The following is a description of a gene set: A major challenge for kidney transplantation is balancing the need for immunosuppression to prevent rejection, while minimizing drug-induced toxicities. We used DNA microarrays (HG-U95Av2 GeneChips, Affymetrix) to determine gene expression profiles for kidney biopsies and peripheral blood lymphocytes (PBLs) in transplant patients including normal donor kidneys, well-functioning transplants without rejection, kidneys undergoing acute rejection, and transplants with renal dysfunction without rejection. We developed a data analysis schema based on expression signal determination, class comparison and prediction, hierarchical clustering, statistical power analysis and real-time quantitative PCR validation. We identified distinct gene expression signatures for both biopsies and PBLs that correlated significantly with each of the different classes of transplant patients. This is the most complete report to date using commercial arrays to identify unique expression signatures in transplant biopsies distinguishing acute rejection, acute dysfunction without rejection and well-functioning transplants with no rejection history. We demonstrate for the first time the successful application of high density DNA chip analysis of PBL as a diagnostic tool for transplantation. The significance of these results, if validated in a multicenter prospective trial, would be the establishment of a metric based on gene expression signatures for monitoring the immune status and immunosuppression of transplanted patients. studied in species Homo sapiens from publication Flechner SM, Kurian SM, Head SR, Sharp SM, Whisenant TC, Zhang J, Chismar JD, Horvath S, Mondala T, Gilmartin T, Cook DJ, Kay SA, Walker JR, Salomon DR (PMID 15307835) Genes down-regulated in kidney biopsies from patients with acute transplant rejection compared to the biopsies from patients with well functioning kidneys more than 1-year post transplant. Human Gene Set: FLECHNER_BIOPSY_KIDNEY_TRANSPLANT_REJECTED_VS_OK_DN, and this is the list of marker genes: HNMT, FMR1 (fragile X messenger ribonucleoprotein 1), SERINC1, SLC16A4, DNPH1 (NCBI Gene Id 10591), AHCYL1, CDKN1C, CLIC4, AKR1C3, SLC17A1, PHKB, RTL8C, DYNLT3, ENPP2 (NCBI Gene Id 5168), RBP4, SLC5A3, R3HDM2, KRIT1, ARMCX2, SELENBP1, DLEU1, SLC4A4, PALM2AKAP2, RNF6 (NCBI Gene Id 6049), ZNF124, IMMT, DDOST, ETFA, STRAP, ABCC4, USP14, PGRMC2, SLC34A1, PTPRD, G3BP1, HSD11B2, CYB5R3, ALDH4A1, PCBD1, GBE1, DPYS (dihydropyrimidinase), CAT, NEK4, SMG1, FMO1, PTPN3, HIBCH, CTSL, MAPK1IP1L, GLYAT, EBNA1BP2, UQCRQ, VDAC1, PRKRA, RAB29, GTF2I, PRPSAP2, CRYAA, KL, ALDH3A2, SERBP1, PEX19, BTBD3, ABCB1, PPP2R3A, SLC31A1, ATP6V0E1, KCNJ15, MFAP3L, TMED10, VTI1B, GLUD2, CFDP1, RAB2A, IGFBP5, HDGF, PRODH2, SLC22A6, CA12, DNM1L (dynamin 1 like), UQCRC1, SALL1, RBPMS (NCBI Gene Id 11030), ATP5F1A, NR1D2, RRAS2, CDC42BPA, SHANK2, AHCY, ZNF148, MMUT, HSPA4, ACY1, H2AZ2 (NCBI Gene Id 94239), CRYAB, GCDH, COX7A1, AZGP1, SOD1, CLASP2, ABCD3, GCHFR, SH3BGR, PMPCB, STRN3, SLC13A3, ECHS1, TNFRSF11B, ATF2, GSTA1, COBLL1 (NCBI Gene Id 22837), HSPD1, ZBTB20, NONO, HSPA8, LARP4 (NCBI Gene Id 113251), PHYH, ESRRG (NCBI Gene Id 2104), AIFM1, PTH1R, SNX2, SMAD4, APOM, ADGRF5, PARD3, ACO1, MRPS18B, PDZRN3, GLOD4, LGALS2, AKR7A3, GATD3, MAF, TERF1, PLPBP, AKR1A1, SLC17A3, ASAP2 (ArfGAP with SH3 domain, ankyrin repeat and PH domain 2), DNAJB9, PRKAR1A, PPM1B, SDHC, CCNG2, GLDC, PCK2, UGT8, ATP6V1A, ENOSF1, GOLGA4, CYP4A11, TMBIM6, BNIP3, FAM169A (NCBI Gene Id 26049), DDX19B, BHMT, HPGD, SEC23A, PTGER3, IGSF3, GRB10, FPGT, UBE2E3, NDUFS4, HADH, ZDHHC17, UGDH, SERPINA5, MME, TST, CSNK2A1, ALDH2, NDUFAB1, DZIP1, VAT1, ALDH9A1, ALB, ACOT13, GHITM, SLC27A2, CYB5A, KHK, TECR, DDX10, GCSH, MARCHF6, PLAAT3, CAP2 (cyclase associated actin cytoskeleton regulatory protein 2), GULP1 (GULP PTB domain containing engulfment adaptor 1), MSMO1, RIDA, MAOA, COPS2 (NCBI Gene Id 9318), SPTSSA, ENTPD5, SORD, CBR4, UGT2B15, YES1, DMXL1, SNRPN, FUCA1, MYO6, CENPS, COL4A4, ALDOB, KIF3A, MXI1, CLTB, HSPA13 (NCBI Gene Id 6782), DUSP3 (dual specificity phosphatase 3), NR3C2, UBA1, UGT2B7, CRYM, PFN2, PAFAH1B1, ACADSB, ADH5, ITGA6, HAGH, APLP2, SYPL1, SDHA, BEX4, NCKAP1, TOMM34, SLC25A36, PIK3C2A, AUTS2, HSPA4L, GOT1, GPD1L, ABCC6, EXPH5, ENPEP, GSTA2, CA4, FABP1, PODXL, COPS5, AGL, HSPB1, SCAMP1, PARG, USP2, SLC22A2, SCP2, SULT1C2, SLC1A1, PRDX3, RTN4, PPP2R1A, SLC25A4, LRP2, AOC1, MAOB, TNPO1, SDC1 (syndecan 1), FKBP2, ACOX1 (acyl-CoA oxidase 1), CALM1, OCLNP1, PCCA, ACSM2A, ACAA2, DSP, AQP1, RPS6KA3, HSPE1, KIF3B, ANK2, GLRX, SLC25A13, RAB1A, ACVR1B, SDHB, SETD3, SLC7A8, CYP4F2, EFHD1, ACO2, ANXA7, SEPHS2, WEE1, MYH10, PDLIM5, PRPF40A, GABARAPL1, ATP5PF, RNASE4, PEX11B, FBXO21, HPD, PLS3, SRSF1, PHB1, AP3D1, EIF1AX, MT1G, ERBB4, ANK3, CLDN8, ITM2B, PSMD11 (proteasome 26S subunit, non-ATPase 11), AQP3, WWTR1, UGT1A10, ASS1, ABCC2, PLEKHB2, ATP5PO, VEGFA, EPS8, CNIH1, MIA2, FYN, SNX4, ABAT, BLTP1, DDT, IDH1, PEX7, KANK1, MTMR4 (myotubularin related protein 4), PEPD, RFK, PDHX (pyruvate dehydrogenase complex component X), UFL1, TXN, NDUFS1, F2R, OAT, CDS1, MDH1, RPP14, CLINT1, PDZK1IP1, PDXDC1, PCK1, GJB1, ACP3, ACAA1, ESD, HMGCL, SC5D, NDUFA5, IGFBP4, KBTBD11, HGD, AGAP1, EPCAM, FECH, DDC (dopa decarboxylase), PDZK1, AKAP11, NREP, COX11, NDRG1, NQO2, SLC39A14 (NCBI Gene Id 23516), FAH, LRPAP1, RHOBTB1, MORF4L2, MTSS1, GRHPR, FBP1, GATM, PPP2CB, YWHAE, CYP3A5, SCAF11, NAT8, MPC2, IDH2, SLC16A7, FAM3C, TRIM44, PEBP1, SEPTIN10, OGG1, NARS1, TEK, MYH11, PEX3, MINPP1, DSTN, ERBB3, QPRT, TMED5, RGN, BBOX1, CTH, PRKCA, FGF9, TOMM70, GLS, DPP4, MICU2, AUH, AK4, TOMM20, IGF1R, EIF3I, SERPINI1, PGRMC1, COPA, PUM1, HPN, ANPEP, PJA2, LRPPRC, RNF14, COX6A1, PRDX2, TOX3, GGT1, PARM1, AFM, SRRM1, RHOBTB3, AKR1C1, RCAN1, PAH, CDK14, GGH (NCBI Gene Id 8836), CGRRF1, SLC7A7, CDH1, ECH1, HTRA1, BBX, ZNF91, ASPA, BPHL, FNDC3A, MPDZ, ACADM, ACSM3, GOT2, SLC26A4, PTGES3, UQCRFS1, ADH6, MT1E, CREB3L2, FAT1, IMPA2, FGF1, RDX, RAB40B, CTBP1, HIPK1, FNBP1L, ANKRD46 (NCBI Gene Id 157567), MT1X, ST13, PLG, GPC5, PGK1, DIO1, OXA1L, FBXO9, PRKCI, PCBP2, TOB1, SLC25A1, NDUFS8, FH, MSH3, CTNNA1, ZMYND11, PRNP, HLTF, RRAGA, IGFBP2, ISCA1, SMAD5, C1QBP, RABGGTB, SLC25A46, PNP, ECI1, NNT, OXCT1, NDUFAF1, CCDC69, CD2AP, ZC3H14, DDX3X, TSC22D1, GPC3, DEFB1, HADHB, CLDN10, GPX3, AKR7A2, HOXD8, CYP17A1, SMPDL3A, ALDH5A1, G6PC1, CD9, CALB1, SLC5A12, SHMT1, CYCS, PDE8A, UQCRC2, TMT1A, DAB2 (DAB adaptor protein 2), CLIC5, VDAC2, ADD3, ATP2A2, XPNPEP2, C11orf58, TRIM2 (tripartite motif containing 2), SLC37A4, TUBB2A, CRYZ, EPHX2, SLC12A3 (solute carrier family 12 member 3), FAM168B, COX7B, CA2, SH3YL1, DLD, SNRPD3, MATCAP2, KDR, GRB14, DST, PIK3R1, NDUFB5, ACOT2, SLC3A2, ALDH6A1, PGM1, TSPYL4, APOH, LAMTOR5, PC, ZNF117, EHHADH, WWP1 (WW domain containing E3 ubiquitin protein ligase 1), COMT, DAP, EPB41L3, BAMBI, ACAT1, FOLH1, KNG1 (NCBI Gene Id 589)